Given this list of marker genes PIEZO1, EPHB4, SOX18, ANGPT2, FOXC2, CELSR1, FLT4, GJC2, DNMT1, here is a description of the gene set: Localized fluid retention and tissue swelling caused by a compromised lymphatic system, affecting mainly the legs. Human Gene Set: HP_PREDOMINANTLY_LOWER_LIMB_LYMPHEDEMA Predominantly lower limb lymphedema species: Homo sapiens